Given this list of marker genes PTHLH, SFRP1, MYT1, BRPF1, FBXL3, SLITRK4, PANK1, ARID1A, FAM76B (family with sequence similarity 76 member B), CAV2, HSF2, EIF4G2, IGIP, DLG5, CACHD1, FBXW11, CAPZA1, HNRNPU, HAT1, FOXG1, CCT2, HNRNPF, ATP2B2, GDF10, STAG1, TFAP4, BEX3, ANTXR2, CD28 (CD28 molecule), AFF4, SRSF10, TTN, ATP2B1, MYO1E, ZNF800, PDE7B, RFX4, DGCR2, ACBD3, SP4, CALCRL, ST6GALNAC3, PABPN1, WIF1, CCNE2, LSM14A, ATP5MC2, FAM193B, PPARA, ST18, NCOA7, MED14, ARID2, VKORC1L1, UBE2D3, NFE2L2, SS18, FOSB, PIM1, BICRAL, RPGRIP1L, CBX1, HYCC2, UBE4A, RARB, PTP4A1, ZDHHC17, ARFGEF1 (NCBI Gene Id 25860), ZNF207, PHTF2, SMPD3, WDFY3, LIFR, MAPK6, UBE2D2, PURA, EIF5 (NCBI Gene Id 1983), NEDD4, ARID5B, SINHCAF (SIN3-HDAC complex associated factor), ZFX, LHX2, CDH2, PAFAH1B1, CBX4, PCDH18, KIAA0232, KPNA1, CC2D2B, STARD8, SOBP, PFKFB2, ARRDC3, GATA3, SON, NAV3, PTGFRN, FMN2, BCLAF3, RNF111, SLC12A2, GLCCI1, DMD, SNAP91, ATXN1, SUCLA2, UNC45A, KBTBD8, NR3C1, NIN, PNRC1, CPEB3, AGRN, UBR3, RIN2, PKNOX1, NRP2, FBXO32, ALS2 (alsin Rho guanine nucleotide exchange factor ALS2), ELL2, ZNF777, SREK1, FMR1, NAA15, PUM1 (pumilio RNA binding family member 1), ETS1, CXCL12, HOXA10, MTPN, CDK19, MEIS2, CCNK, KAT6A, CREBRF, ZEB2, ITSN2 (NCBI Gene Id 6454), E2F8, GCNT2, PAPPA, SIN3A (SIN3 transcription regulator family member A), PLAG1, ESRRG, EPB41, PTPN9, RHOBTB1, SMARCA1, BACH2 (BTB domain and CNC homolog 2), EDAR (NCBI Gene Id 1898), PPP3R1, TFRC, NR2F2, SEMA6D, IDH2, MSI1, PPP1R16B, APPBP2, RIC8B, PAX3, ALDH1A3, ZCCHC2, SENP7, GSPT1, AHCY, TRIB1, TBL1XR1, MSX1 (msh homeobox 1), HDHD2, CCDC88A, CELF2, TRIO, CDH11, SLC23A2, SORCS3, TBX1, FNDC3A, CLK1, CPEB2, FOXO1, JPH1, MEIS1, ANK2, WTAP, PDE4D, RGS16, ZBTB18, C19orf73, CHTOP (chromatin target of PRMT1), QKI, ZIC4, SEMA6A, USP42, NKAPD1, MARCKS, SLC7A11, MAP7D1, LGR4, RBM12, ACSL4, here is a description of the gene set: Human Gene Set: ATACTGT_MIR144 Genes having at least one occurence of the motif ATACTGT in their 3' untranslated region. The motif represents putative target (that is, seed match) of human mature miRNA hsa-miR-144 (v7.1 miRBase). species: Homo sapiens